The following is a description of a gene set: Human Gene Set: GOBP_L_ASPARTATE_IMPORT_ACROSS_PLASMA_MEMBRANE The directed movement of L-aspartate from outside of a cell, across the plasma membrane and into the cytosol. species: Homo sapiens, and this is the list of marker genes: SLC1A4, SLC1A6, SLC1A1, SLC1A3, SLC1A5, SLC1A2